The following is a description of a gene set: Human Gene Set: WP_ENDOMETRIAL_CANCER Endometrial cancer species: Homo sapiens, and this is the list of marker genes: BAX, KRAS, MAPK1, PIK3R3, POLK, CASP9, HRAS, AXIN1, LEF1, APC, TCF7, GADD45B, FGF2, SOS1, CDH1, ILK, PIK3R2, MAPK3, AKT2, ELK1, BAK1, RAF1, TCF7L1, GRB2, SOS2, GADD45A, PIK3R1, BRAF, NRAS, CTNNB1, TP53, DDB2 (NCBI Gene Id 1643), AKT1, FGF1, PIK3CB, EGFR, MAP2K1, APC2, CTNNA2, AKT3, EGF (epidermal growth factor), CDKN1A, FGFR1, TCF7L2, CCND1, GSK3B, FGFR3, FOXO3, FGFR2, CTNNA1, FOS, MAP2K2, PIK3CA, PDPK1, AXIN2, MYC, CTNNA3, PTEN, GADD45G, PIK3CD, ARAF, ERBB2, BAD